The following is a description of a gene set: Any process that activates or increases the frequency, rate or extent of neural precursor cell proliferation. Human Gene Set: GOBP_POSITIVE_REGULATION_OF_NEURAL_PRECURSOR_CELL_PROLIFERATION species: Homo sapiens, and this is the list of marker genes: FGF2, FOXG1, TOX, FZD3, PITX3, OTP, FZD9, VEGFC, PROX1, ITGB1, NR2E1, DRD2, LYN, CTNNB1, NES, ASCL1, DISC1, DISP3, WNT3A, CX3CL1, KDM1A, VEGFA, SMO, DCT, MDK, IGF1, LHX2, ELL3, ZNF335, ID4, WDR62, NOTCH1, RYK, SBNO1, ASPM, SHH, DMRTA2, SOX10, CX3CR1 (NCBI Gene Id 2836), LRP2, PAX6, GNAI2, EGF, GLI3, INSM1, NAP1L1, GPR37L1, RASSF10, CDON, FLNA, SMARCD3, HIF1A, ADGRG1, DLL4